Given this list of marker genes P2RX2, P2RX3, P2RX5, P2RX4, P2RX6, P2RX7, P2RX1, here is a description of the gene set: species: Homo sapiens Enables the transmembrane transfer of a monoatomic cation by a channel that opens when ATP is bound by the channel complex or one of its constituent parts on the extracellular side of the plasma membrane. Human Gene Set: GOMF_EXTRACELLULARLY_ATP_GATED_MONOATOMIC_CATION_CHANNEL_ACTIVITY